Given this list of marker genes TXNRD2, TXNRD1, TXNRD3, TXNDC2, TXN, PGK1, SELENOT, NXN, TXNDC17, here is a description of the gene set: Catalysis of the reaction: protein-dithiol + NAD(P)+ = protein-disulfide + NAD(P)H + H+. species: Homo sapiens Human Gene Set: GOMF_PROTEIN_DISULFIDE_REDUCTASE_NAD_P_H_ACTIVITY